The following is a description of a gene set: Enables the transfer of quaternary ammonium groups from one side of a membrane to the other. Quaternary ammonium groups are any compound that can be regarded as derived from ammonium hydroxide or an ammonium salt by replacement of all four hydrogen atoms of the NH4+ ion by organic groups. species: Mus musculus Mouse Gene Set: GOMF_QUATERNARY_AMMONIUM_GROUP_TRANSMEMBRANE_TRANSPORTER_ACTIVITY, and this is the list of marker genes: Slc22a15 (solute carrier family 22 (organic anion/cation transporter), member 15), Slc22a3, Slc25a20, Slc6a20a, Slc22a2 (NCBI Gene Id 20518), Slc22a8, Slc22a21, Slc6a14, Slc44a4, Slc22a16, Slc25a19, Slc16a9, Slc22a5, Slc22a1, Slc22a4, Slc25a29